Given this list of marker genes JMJD6, MEGF10, SCARB1, FCN1, FCN3, PEAR1, FCN2, here is a description of the gene set: Human Gene Set: GOBP_RECOGNITION_OF_APOPTOTIC_CELL The process in which a cell interprets signals (in the form of specific proteins and lipids) on the surface of a dying cell which it will engulf and remove by phagocytosis. species: Homo sapiens